The following is a description of a gene set: part of: Metabolism of nitric oxide: NOS3 activation and regulation Reactome Pathway: eNOS activation species: Mus musculus electronically inferred by orthology from the curated human pathway This event has been computationally inferred from an event that has been demonstrated in another species.<p>The inference is based on the homology mapping from PANTHER. Briefly, reactions for which all involved PhysicalEntities (in input, output and catalyst) have a mapped orthologue/paralogue (for complexes at least 75% of components must have a mapping) are inferred to the other species., and this is the list of marker genes: Calm1, Zdhhc21, Lypla1, Cyb5b, Cav1